The following is a description of a gene set: Any process that modulates the frequency, rate, or extent of T cell mediated immunity. Human Gene Set: GOBP_REGULATION_OF_T_CELL_MEDIATED_IMMUNITY studied in species Homo sapiens, and this is the list of marker genes: IL1B, TRPM4, HLA-F, IFNA2, CD80, TRAF6, WAS, KLHL22, TNFSF4, PDCD1, PTPRC, RAET1G, FADD, HLA-G, STX7, ULBP3, FUT7, MR1, IL4, IL7R, HLA-E, IL12RB1, GATA3, ZP3, IL23A, CD1E, RAET1E (retinoic acid early transcript 1E), CYRIB, HMGB1, DUSP22, MAP3K7, FZD5, PVR, PRKAA1, B2M, CD7, MALT1, CD81, LILRB1, CLC, CD55, ARG1, NCKAP1L, CD1D, CD1C, TAP2, FCGR2B, PRKCZ, PPP3CB, CCR2, IL6, ULBP2, RIPK3, ULBP1, IL4I1, AZGP1, IL20RB, RSAD2, P2RX7, FBXO38, HLA-DRB3, YWHAG, XCL1, SECTM1 (NCBI Gene Id 6398), LILRB4, IL23R, KLRC1, CLEC4G, CD274, MAPK3, KLRD1, HLA-DRB1, DENND1B, IL12A, SASH3, SPN, SMAD7, CD1B (CD1b molecule), HLA-H, FOXP3, IL1R1, SLC22A13 (NCBI Gene Id 9390), USP5, NECTIN2, IL18R1, ARID5A, IFNB1, SLAMF1, TRAF2, HSPD1, ZBTB1, TBX21, AHR, RAET1L, HLA-B, CEACAM1, UFL1, IL18, HLA-C, AGER, HLA-A, NLRP3, TNFRSF1B, HLA-DRA, CD1A, HFE, IL12B